The following is a description of a gene set: studied in species Homo sapiens Genes down-regulated in the immature neuron cell line: control versus infected with western equine encephalitis viruss. Human neuronal differentiation alters responsiveness to innate immune stimuli and virus infections. We used microarrays to examine the transcriptional responses of the human BE(2)-C neuroblastoma cell line to infection with western equine encephalitis virus (WEEV). Human Gene Set: GSE16451_CTRL_VS_WEST_EQUINE_ENC_VIRUS_IMMATURE_NEURON_CELL_LINE_DN from publication Peltier DC, Simms A, Farmer JR, Miller DJ (PMID 20483728), and this is the list of marker genes: TMA16, RACGAP1, DHFR, ASF1B, UBE2F (ubiquitin conjugating enzyme E2 F (putative)), PPFIBP1, PIGF, FCRL1, CEP170B, ZMAT3, AEN, MYCBP, IPO4, SLC7A1, TIMM8A, BTBD19, NARS1, DYRK3, TMEM35A, METTL4, AKR1C3, RARS2, N4BP1, RNF214, GPR171, ZNF22, SLC30A4, MFSD12, SLC9B2, C8orf76, EI24, GFER, RAD54L, BCAT1, SGO1, CDC6, SPSB1, ZNF593, UBL4A, IFT57, PRPF31, IFT25, NME6, MRRF, CENPK, PTPRS, GAR1, EHD4, COQ3, ALPK2, EGLN3, CYP51A1, C15orf48, PBK, HAX1 (NCBI Gene Id 10456), MAFG, GPR89B, DSN1, FRRS1, ZBED5, COMMD9, SNX12, MAP3K20, SEMA7A, POLE, LEO1, P4HB, CNDP2, CPD, HLA-DMA, TPX2, NCAPH, ATAD2, EIF4EBP1, RUFY3, NUP43, TFDP2, SPC25, GLRX2, IMPDH2, LPGAT1, CINP, TRAIP, METTL2B, SYCE2, SNHG32, CTNNA1, INTS7, GJA1, LRRC75A (NCBI Gene Id 388341), ERAP1, TLE6, DCTPP1, TSEN2, METTL1, IFT172, GINS1, TMPRSS3, CDKN1A, UMPS, ATP1A2, TBX21, NNMT, NAPB, SMYD3, POLA1, PSRC1, DIP2C, FANCI, LITAF, CCHCR1, CENPP, BLTP3A, FAM72A, CPSF4, ADAT3, NCAPG, COX7A1, SLC66A1, CDCA5, COX19, SPP1, CAVIN3, NUF2, MRPL48, EIF2D, NOC3L, PSAT1, DPCD, LAIR1, OXCT1, PAFAH2, EXOC2, CYP11A1, TRMT5 (tRNA methyltransferase 5), ANXA3, DNAAF4, SLC39A8, MAPKAPK3, DNAAF2, PSAPL1, IDE, SHCBP1, NEK6, MCM10 (minichromosome maintenance 10 replication initiation factor), ZNF580, RRM2, MRPL41, TCF19, SNORD89, MARS1, NICN1, ASNS, IRF8, RAD51, MTG1, IARS1, GEMIN6, HTT, SLC39A14, RHOQ, PLSCR1, STIL, TIGD2, UBE3D, CARNMT1, CDK6, LONRF3, PSME3, GLOD4, SLFN12, AARS1, PPP2R1B, CKS1B, RNF149, MT1E, WDR12, GCSH, ALCAM, SLC5A3, RSPH3, AMZ1, PSMD1, KMT5A, FABP5, SEPHS1, MYO1C, AKIP1, ST7, COQ4, RNMT, RBPJ, TDRKH, STAB1, NCAPG2, NUDT1, CHEK1, MPZL1, VCL, DSCC1